The following is a description of a gene set: species: Mus musculus Binding to hyaluronic acid, a polymer composed of repeating dimeric units of glucuronic acid and N-acetyl glucosamine. Mouse Gene Set: GOMF_HYALURONIC_ACID_BINDING, and this is the list of marker genes: Impg2, Impg1, Bcan, Hmmr, Itih2, Itih1, Chodl, 2300002M23Rik, Stab2, Hapln1, Usp17le, Acan, Tnfaip6, Stab1, Usp17lb, Hapln4, Ncan, Itih4, Layn, C1qbp, Habp4, Cd44, Vcan, Usp17lc, Usp17ld, Hapln2, Usp17la, Hyal2, Lyve1, Hapln3, Cemip